The following is a description of a gene set: species: Homo sapiens Any process that modulates the frequency, rate or extent of organelle assembly. Human Gene Set: GOBP_REGULATION_OF_ORGANELLE_ASSEMBLY, and this is the list of marker genes: HSF1, PINK1, TBC1D5, CDK5RAP2, PRICKLE1, SNX30, NOTO, LCP1, MDM1, EML3, PRKAA1, EVI5, SNX7, TBC1D20, TBC1D21, MNS1, EFNB1, GDI2, TBC1D2B, PPP1R35, TBC1D8, FEZ2, WDR45, CHMP7, RAB3GAP1, RALB, ADAMTS16, CEP135, ALMS1 (ALMS1 centrosome and basal body associated protein), ATG5, LUZP1, EHMT2, GPSM2, TRIM37, LATS1, KIF24, ODAD3, IFT88, TBC1D17, TRIM32, CHMP3, DYNLT2B, ATG3 (autophagy related 3), NPM1, ABL1, INTU, ARF4, LRRC4B, TBC1D15, VPS11, FSCN1, RP1, RCC1, CNOT1, TESK1, LIMA1 (NCBI Gene Id 51474), KCTD17, CHMP4C, HTT, SDCBP, RDX, CNOT6, PDCD6IP, TBC1D12, MTMR3, DYNC2LI1, CCDC88A, RNF4, RABEP2, HNRNPU, STX18, HSPA1B, KAT2A, CEP295NL, IFT140, CSF2, MPHOSPH9, CDK10, SDC1, TBC1D2, ATG2A, SAXO1, ARHGAP35, LRRTM2, FGFR1 (NCBI Gene Id 84151), PIKFYVE, KAT2B, RAB11A, TBC1D16, NUP62, TAPT1, GSN, ZMYND10, WDPCP (WD repeat containing planar cell polarity effector), SNX4, PTPRD, UBQLN2, SEC22B (SEC22 homolog B, vesicle trafficking protein), GRID2, ARHGEF5, IL1RAP, HSPA1A, ATMIN, CENPJ, TTBK2, USP10, MARCHF7, IL5, CHMP4B, SDC4, RAB3GAP2, EPHB2, CHMP6, BECN1, ATM, CEP97, RABGAP1, CHMP5, PIP4K2B, GAP43, USP6NL (NCBI Gene Id 9712), TBC1D22A, HCK, AKT1, ARHGEF9 (Cdc42 guanine nucleotide exchange factor 9), SPICE1, DRG1 (NCBI Gene Id 4733), PIP4K2C, NUPR1, CROCC, RAB1B, BRCA1, WDR44, MTOR, SENP6, CDKL1, RHOA, SASS6, NBDY, MCIDAS, CHEK2, CASKIN1, CNOT6L, CCDC15, ULK1, STAM, CHMP2A, TBC1D10C, CAPG, CHMP4BP1, WIPI1, TBC1D9B, TBC1D3, TPR, CHMP2B, EVI5L, PLK1, MAPK15, TNF, TBC1D22B (TBC1 domain family member 22B), YAP1, CRIPT, FEZ1, SPAG5, MAK, DYNC1H1, DCDC2, PTK2B, C9orf72, PHF23, PATL2, CDKL5, SCFD1, CEP295 (centrosomal protein 295), BBS4, SNX18, RAB11FIP3, C10orf90, MAP4, TBC1D10B, SPTBN2, STYXL1, LIMK2, LPAR1, TBC1D14, RNF5, TBC1D24, SMAD4, CHMP1B, SYNE2, PRKAA2, TBC1D7, PAN3, TBC1D30, NF2, RIPOR2, ELAPOR1, FUZ, TBC1D19, SH3GLB1, SDCCAG8, LRSAM1, RNF186, VPS4B, CCP110, KIF9, PLK2, CNOT2, CCSAP, CYLD, ENTR1, SEPTIN9, MAPK9, ODF2, POC1B, CNTROB, TSG101, SMCR8, ODF2L, MSN, PIP4K2A, TBC1D10A, IFT20, TBC1D13, CEP76, STIL (STIL centriolar assembly protein), SEPTIN7, LRRK2, UBAP2L, SGSM3, RAB5A, CAV3, PTPRS, PLK4, NUMA1, CHMP1A, TMEM39A, PAN2, MARK4, ABI3 (ABI family member 3), LRFN4, EZR, WRAP73, TBC1D1, CEP120, LRFN1, HAP1, RBM14, CAPRIN1, DZIP1, MOAP1, CBLN1, CHMP4A, SRC, MTM1 (NCBI Gene Id 4534), GSK3B, TRAPPC12, TCHP